Given this list of marker genes PLEKHA7, KIFC3, CAMSAP3, TJP1, INAVA, FERMT2, MTSS1, here is a description of the gene set: The maintenance of an adherens junction. An adherens junction is a cell-cell junction composed of the epithelial cadherin-catenin complex at which the cytoplasmic face of the plasma membrane is attached to actin filaments. species: Homo sapiens Human Gene Set: GOBP_ADHERENS_JUNCTION_MAINTENANCE